The following is a description of a gene set: species: Homo sapiens Plethora Human Gene Set: HP_PLETHORA, and this is the list of marker genes: TP53, SH2B3, ATRX, CDH23, EPOR, JAK2, USP48, VHL, NR3C1, ARMC5, USP8, KDM1A, GNAS, BRAF